Given this list of marker genes Gata3, Usf2, Kat5, H2bc12, H3c11, H2bc13, H4c9, H3c3, H4c3, Esr1, Polr2a, H2bc11, H3c4, H3c8, H3c15, H4c4, Polr2f, H3f3a, Polr2k, Polr2e, H4c11, Gtf2f1, H4c17, Polr2b, H2bc8, Ncoa1, Kdm1a, H2bc7, H4c6, Foxa1, H4c8 (NCBI Gene Id 69386), H3c6, H4c2, H2bc27, H4c14, H3c2, Cbfb, Gtf2a1, H2bc1, Polr2c, Ep300, H2bc22, Gtf2f2, H3c1, H2bc15, Cited1 (NCBI Gene Id 12705), Fkbp4, Med1, H4c1, H4c12, Tbp, H2ac1, H3c7, H2bc9, H2bc3, H3c10, H4c18, Carm1 (NCBI Gene Id 59035), Polr2i, Polr2l, H3c13, Erbb4, here is a description of the gene set: part of: ESR-mediated signaling species: Mus musculus Reactome Pathway: Estrogen-dependent gene expression This event has been computationally inferred from an event that has been demonstrated in another species.<p>The inference is based on the homology mapping from PANTHER. Briefly, reactions for which all involved PhysicalEntities (in input, output and catalyst) have a mapped orthologue/paralogue (for complexes at least 75% of components must have a mapping) are inferred to the other species. electronically inferred by orthology from the curated human pathway